Given this list of marker genes TP63, COX7B, DVL3, ORC6, GLI1, DVL1 (NCBI Gene Id 348497), SMAD4, NDUFB11, HCCS (holocytochrome c synthase), PRKACA, WNT5A, ANKRD11, ORC1, FZD2, PRKACB, PTDSS1, DYNC2LI1, EVC, PIEZO2, KRAS, ISL1, C2CD3, CDT1, SRY, CDC45, ORC4, EVC2, CDC6, GMNN, here is a description of the gene set: studied in species Homo sapiens Human Gene Set: HP_EPISPADIAS Epispadias is a urogenital malformation characterized by the failure of the urethral tube to tubularize on the dorsal aspect. Unlike in hypospadias, where the meatus is on the ventral aspect, children with epispadias have a wide-open urethral plate on the dorsum. It is commonly seen as a component in the spectrum of bladder exstrophy-epispadias-complex. Isolated epispadias constitutes less than 10 percent of the total cases of epispadias. Epispadias